The following is a description of a gene set: species: Homo sapiens Any process that results in a change in state or activity of a cell or an organism (in terms of movement, secretion, enzyme production, gene expression, etc.) as a result of a corticosterone stimulus. Corticosterone is a 21 carbon steroid hormone of the corticosteroid type, produced in the cortex of the adrenal glands. In many species, corticosterone is the principal glucocorticoid, involved in regulation of fuel metabolism, immune reactions, and stress responses. Human Gene Set: GOBP_RESPONSE_TO_CORTICOSTERONE, and this is the list of marker genes: CRH, NPAS4, COMT, AVPR1A, FOS, FOSB, CCND1, HDAC6, NTRK3, FOXO3, NEFL, UCN3, PRKN, PRKCA (protein kinase C alpha), CALM3, AANAT